The following is a description of a gene set: Human Gene Set: REACTOME_SIGNALING_BY_CSF3_G_CSF species: Homo sapiens Signaling by CSF3 (G-CSF), and this is the list of marker genes: CUL5, HCK, PTPN11, RNF7, JAK1, UBA52, GAB2, STAT5B, UBE2D1 (ubiquitin conjugating enzyme E2 D1), SYK, UBB, CSF3R, KRAS, JAK2 (Janus kinase 2), ELOC, STAT3 (NCBI Gene Id 6774), TYK2, LYN (LYN proto-oncogene, Src family tyrosine kinase, NCBI Gene Id 4067), UBE2D3, SOCS1, ELOB, GRB2, STAT1, UBC, SHC1 (NCBI Gene Id 6464), STAT5A, UBE2D2, SOCS3, CSF3 (NCBI Gene Id 170794), RPS27A